The following is a description of a gene set: Neighborhood of ACP1 species: Homo sapiens Neighborhood of ACP1 acid phosphatase 1, soluble in the MORF expression compendium Human Gene Set: MORF_ACP1, and this is the list of marker genes: BAG6, CIAO1, HNRNPD, TCP1, COPE, SRSF2, HDAC1, TMEM123, PSMB1, EFCAB14, CTBP1, CAP1, DNAJC8, FOXJ3, OXA1L, GNAS, VDAC2, MED12, H2AZ2 (H2A.Z variant histone 2), TOMM20, NARS1 (asparaginyl-tRNA synthetase 1), PDIA6 (NCBI Gene Id 10130), ERCC5, ZFPL1, MACROH2A1, HMGN1, EIF3I, TARDBP, SNRNP200, ARPC3, SRSF3, CCT7, NAGLU (NCBI Gene Id 4669), RAB14, DR1, LRPPRC, SRRM1, CBX3, TRIM28 (NCBI Gene Id 96054), HDGF, NACA, DDX39B, HNRNPR, SRP72, ANAPC5, DHX15, FUS, CS, ERH, KHDRBS1, CHD4, ZC3H15, GANAB, MAPRE1, SMARCC1, XPO7, ATP5PO, DDX49, EIF3D, BUB3, XPO1, PARK7, EIF1AX, NPM1, RAB8A, RSL1D1, PRRC2C, EIF3H, HNRNPA1, DPF2, HGS, PPIG, NONO, TAX1BP1, ILF2, TERF1, SF3A1, SREBF2, GCN1, SF3A2, HSP90AB1, YWHAQ (NCBI Gene Id 10971), BRD2, NCL, RPL10A, PSMB7, CNPPD1, EIF3G, EIF3M, TUBA3C, UBE2L3, GDI2, BTF3 (NCBI Gene Id 689), EIF4A1, SNX3, TAF11, SUMO2, UQCRH, EIF4H, NAP1L4, DEK, POM121, USP22, LSM14A (NCBI Gene Id 91161), YBX1, ANP32A, RPS12 (NCBI Gene Id 6206), PSMA1, BRD8, HADHA, EIF3F, TATDN2, TCEA1, NAP1L1, EIF3K, BCL7B, EIF3E, DDX19A, FAM168B, RPL5, HNRNPC, PRPF8, NDUFV1, DIAPH1, RPL22, TEX261, RPL18, GNB2, NDUFA7, EIF4G2, CSNK2B, EIF4B, ANP32B, PCBP2, SNRPE, EIF4A2, RHEB, LSM7, RPS27A, THOP1, SUMO3, CCNI, DDOST, WDR1, ATF4, JTB, UBA2, PHIP (pleckstrin homology domain interacting protein), SART1, PTGES3, HNRNPM, MRPL9, SLC25A3, STARD7, PHB2, SRSF9, SRP14, SAFB, RNPS1, ATXN10, RHOA, NDUFS4, DHX38, YME1L1, BAZ2A, SNRNP70, CSK, TUFM, KXD1, TRA2B, POLE3, ILF3, HNRNPUL1, LYPLA1, PTP4A2, RAD23A, U2AF1, RABGGTB, SET, RO60, TIAL1, ATP5F1A, HINT1, DKC1, GNB1, UBE2I, ERP29, RPL14, PUM1, ZFC3H1, XRCC6, PNN, RPLP2, CCT2, PPIE, ACP1, HSP90AA1, TLK1, DUT, TTC1, UQCRFS1, ATAD2B, UBE2N, HNRNPK, NSA2, STRAP, YWHAZ, CALM3, DRG1, RPL21, XRCC5